Given this list of marker genes Grm4, Adrb2, Vps54, Drd2, Nlgn2, Grid2, Nf1, Nps, Zzef1, Grin2d, Cacng2, Ntrk2, Cacng4 (NCBI Gene Id 54377), Ngfr, Grm1, Gria3, Abtb3, Grm8, Ror2, Gria2, Shank3, Grik5, Mapk8ip2, Cacng7, Htr2a, Grm6, Ophn1, Slc17a6, Clcn3, Cdh8, Grm3, Napb, Slc17a7 (NCBI Gene Id 72961), Adora2a, Als2, Cacng5, Iqsec2, Kcnj8, Aph1c, Plat, Atad1, Grin2a, Frrs1l, Unc13a, Nlgn1 (neuroligin 1), Shc3, Npy2r, Ucn, Egfr, Htr1b, Fxr1, Cnr1, Ccl2, Myo5a, Lrrk2, Grin3b, Cacng8, Ext1, Drd1, Grm7, Pla2g6, Cnih2, Nr3c1, Rab3gap1, Gria1, P2rx1, Hdac6, Stxbp1, Ptgs2, Cckbr, Dtnbp1, Glul, Cacna1a, Oxtr, Plppr4, Psen1, Adora1, Shank2, Prkn, Rnf167, Kmo, Tshz3, Napa, Cnih3, Serpine2, Pak1, Slc38a2 (solute carrier family 38, member 2), Nrxn1, Dcdc2a, Grm2, Abcc8, Mef2c (NCBI Gene Id 71350), Syt1, Nlgn3, Cdh2 (cadherin 2), Grid1, Tnr, Ccr2, Grin3a, Homer1, Grik2, Dscam, Cln3, Cacnb4, Unc13c, Grik4, Disc1, Ptk2b, Dkk1, Grin1, Reln, Tprg1l, Unc13b, Grik3, Grm5, Prkaca, Grin2b, Cacng3, Grik1, Ntrk1, Slc17a8, Cdk5 (cyclin dependent kinase 5), Drd3, Adcyap1, Aph1b, Gria4, Dgki, Grin2c, Clstn3, here is a description of the gene set: Mouse Gene Set: GOBP_SYNAPTIC_TRANSMISSION_GLUTAMATERGIC species: Mus musculus The vesicular release of glutamate from a presynapse, across a chemical synapse, the subsequent activation of glutamate receptors at the postsynapse of a target cell (neuron, muscle, or secretory cell) and the effects of this activation on the postsynaptic membrane potential and ionic composition of the postsynaptic cytosol. This process encompasses both spontaneous and evoked release of neurotransmitter and all parts of synaptic vesicle exocytosis. Evoked transmission starts with the arrival of an action potential at the presynapse.